Given this list of marker genes PRKAR2B, PRKACG, PRKAR2A, PRKACA, PPP3CC, PPP1R1B, PDE4C, PPP3R1, PDE4A, PPP3CA, PRKAR1A, PDE4B, PRKACB, CALM1, CDK5, PPP2R5D, PPP2CB, PPP2R1A, PPP2CA, PPP3CB, PDE4D, PRKAR1B, PPP1CA, PPP2R1B, here is a description of the gene set: DARPP-32 events species: Homo sapiens Human Gene Set: REACTOME_DARPP_32_EVENTS